Given this list of marker genes TERT, AURKA, KCNN3, PDGFRL, TSC1, CHEK2, PTCH1, PDGFB, PLCD1, NRAS, BUB1B, AXIN2, FLNA, SPTBN1, PAX7, KIT, AKT1, PTCH2, FOXO1, ANGPT2, PDGFRB, SLC22A18, ANTXR2, DLC1 (NCBI Gene Id 94517), TSC2, MDM2, BAP1, FAM20A, KLLN, BRAF, KRT17, PAX3, ELMO2, BUB1, FH, MCC, CDKN2C, IFNG, NF1 (neurofibromin 1), CDKN2A, USF3, RSPRY1, SRC, CEP57, PDE11A, NOTCH3 (notch receptor 3), RAD54B, MAP2K1, FASLG, HRAS, EPHB4, CCND1, FLCN, COL4A6, BAX, CDC73, KCNH1, PLA2G2A, CTNNB1, SDHC, DCC, PIK3CA, ATP6V1B2, COL1A1, PMS1, SUFU, DICER1, MTAP, SMO, IL6ST, SDHB, DHCR24, MEN1, TLR2, PTPRJ, EPCAM, MLH1, EP300, CDKN2B, TP53, CDKN1B, ASPSCR1, PMS2, GJC2, TRAF7, TRIP13, FGFR3, FLT4, REST, COL4A5, SPRED1, LRP1, BUB3, SDHD, NF2, KRAS, PRKAR1A, PTPN11, MAD1L1, SMARCE1, SOS1, KEAP1, NBN, PIEZO1, SEC23B, PTPN12, FAM20C, PTEN, SMARCB1, ABCA5, FAS, CASP10 (caspase 10), APC, MSH2, TGFBR2, MLH3, CDKN1A, FOXC2, PRLR, MSH6, here is a description of the gene set: Soft tissue sarcoma A type of sarcoma (A connective tissue neoplasm formed by proliferation of mesodermal cells) that develops from soft tissues like fat, muscle, nerves, fibrous tissues, blood vessels, or deep skin tissues. Human Gene Set: HP_SOFT_TISSUE_SARCOMA species: Homo sapiens